The following is a description of a gene set: Human Gene Set: REACTOME_INSULIN_RECEPTOR_RECYCLING studied in species Homo sapiens Insulin receptor recycling, and this is the list of marker genes: ATP6V1E1, ATP6V1E2, ATP6V1G3, ATP6V0A1, ATP6V0A4, ATP6V1G2, ATP6V1C1, ATP6V0E2 (NCBI Gene Id 155066), ATP6V1F, PTPRF, ATP6V0C, ATP6V0D1, ATP6V1B1, ATP6V0E1, PTPN1, TCIRG1, ATP6V0D2, IDE, ATP6V1D, ATP6V0A2, ATP6V1A, ATP6V0B, CTSD, ATP6V1H, ATP6V1G1, INSR, ATP6V1B2, ATP6AP1, ATP6V1C2, INS (NCBI Gene Id 3630)